Given this list of marker genes CXXC1, WDR5, SETD1A, HCFC2, DYDC1, RBBP5, DYDC2, BOD1L1, WDR82, ASH2L, HCFC1, DPY30, BOD1, WDR5B, SETD1B (SET domain containing 1B, histone lysine methyltransferase), here is a description of the gene set: A conserved protein complex that catalyzes methylation of histone H3. In Saccharomyces the complex contains Shg1p, Sdc1p, Swd1p, Swd2p, Swd3p, Spp1p, Bre2p, and the trithorax-related Set1p; in mammals it contains the catalytic subunit (SETD1A or SETD1B), WDR5, WDR82, RBBP5, ASH2L/ASH2, CXXC1/CFP1, HCFC1 and DPY30. Human Gene Set: GOCC_SET1C_COMPASS_COMPLEX studied in species Homo sapiens